The following is a description of a gene set: Human Gene Set: GSE13173_UNTREATED_VS_IL12_TREATED_ACT_CD8_TCELL_DN from publication Markiewicz MA, Wise EL, Buchwald ZS, Cheney EE, Hansen TH, Suri A, Cemerski S, Allen PM, Shaw AS (PMID 19155481) Genes down-regulated in splenocytes from OT-1 TCR transgenic mice: control versus IL-12 treatment. studied in species Homo sapiens The goal was to determine how IL-12 affects gene expression by murine CTL., and this is the list of marker genes: DNM1L, TPTE, PDE4DIP, BLTP3B, MIS12, FOLR2, RNF25, CCDC70, GRINA, UTP14A, CBFA2T2, TBL1X, USP37, SHROOM2 (NCBI Gene Id 357), BCAP29, DARS1, LY96, MIR217, VPS33B, IDI1, RIBC1, LCN8, CX3CR1, RNF11, SNX16, NSMCE2, UBE2Q2, MRPL32, LARP4, RNF115, TRO, NUSAP1, DNAJB2, MMD, HACD2 (3-hydroxyacyl-CoA dehydratase 2), MIR30A, CENPC, GNA13, RAD50, DEK, PVT1, TPMT, TBC1D7, CASP3, CPEB2, SBF2, SRGAP2, MFSD6, NAV2, CEP192, PRDM5, CIBAR1, APAF1, NPEPPS, AIFM2 (AIF family member 2), MRFAP1, CEP170, SLAMF6, LAGE3, FBXW11, HNRNPD, GNL2, ORC2, POLK, PHACTR4, GSPT2, HELQ, MRGPRF, SAMSN1, ADSS2, POGLUT3, ATP9B, DHX29, EEF2K, CYSLTR2, TERF2IP, PLPP1, USP1, ODF2L, TMX1, NR4A1, HAUS6, ACACA, VNN1, ACER3, DTX3, TNPO3, PCGF6, CCDC163, TIAL1, UHMK1 (U2AF homology motif kinase 1), FANCM, PTMA, DNAJC3, SLC33A1, TMBIM1, NEPRO, ARHGAP5, MDM2, FAF2, PTGER2, GPR34, RFX5, CDC14A (cell division cycle 14A), SLC30A6, SH3BGRL, CLPX, GOLGA7, SESTD1, KPTN, PLS3, RAF1, CEP83, ZC3H15, SERPINB12 (NCBI Gene Id 89777), NFYA, ZHX3, ASZ1, LGR4, EIF2AK4, PPP1R15B (protein phosphatase 1 regulatory subunit 15B), CTSD, HNRNPA3, CUL2, AHRR, HNRNPLL, SCN7A, TBC1D5, CENPF, CCDC122, PPP1R3B, NEK4, HOOK1, HINFP, ARHGAP12, ABCA7, SCNN1G, POMT1, MPHOSPH10, A1CF, USP46